Given this list of marker genes ADH7, AKR1C2, HSD3B2, DKK3, SRD5A3, FURIN, DHRS11, ARNT, SRD5A2, MEP1A, CYP46A1, NAGLU, SLC16A2, KLK6, ZMPSTE24 (NCBI Gene Id 10269), BMP2, ASMT, HSD17B7, RDH16, RDH10, AKR1C1, RDH12, CRHBP, YIPF5, BCO1, CYP3A5, SRD5A1, CTSB, TIPARP, BMP6, CMA1, RETSAT, CYP2C18, FSHB, ADH1C, LIPE, PAX8, DPP4, PCSK1, SLC30A5, RPE65, UGT2B28, CYP19A1, ATP1A1, PCSK6, ACE, ALDH1A3, HSD17B3, STUB1, ADH1B, CYP27C1 (cytochrome P450 family 27 subfamily C member 1), DGAT2, PCSK1N, RDH5, HSD17B2, PTPN11, ERO1B, RDH13, PCSK4, SULT1A4, EGR1, MME, DGKQ, CYP26C1, ADH4, CRABP2, AKR1C4, TSPO, BBS1 (Bardet-Biedl syndrome 1), CPA4, CYP17A1, DIO2, TG, SLC30A8, SELENOM, DUOX1, SDR16C5, SCG5, MBOAT4, CPQ, RBP1 (NCBI Gene Id 5947), GHR, PLA2G7, DUOXA1, UGT2B17, WNT4, SLC16A10, GNB3, HSD17B11, SLC5A5, FSHR, ESR1, PREP, GATA3, PLEKHA1, LRAT, IL4I1, SULT1A3, DUOXA2, ALDH1A1, CYP26B1, UGT1A1, CYP1B1, ADH6, NR3C1, DGAT1, PCSK7, SCPEP1 (NCBI Gene Id 59342), SDR9C7 (NCBI Gene Id 121214), RDH14, AFP, CACNA1H, CYP3A7, ADH1A, SGPL1, MED1, UGT2B11, UGT1A7, CYP26A1, ALDH1A2 (NCBI Gene Id 8854), FFAR3, SPP1, LEP, SLC26A7, HPN, DHRS2, DIO1, FOXA1 (NCBI Gene Id 3169), GHRHR, DHRS4, PNPLA4, IYD, HID1, DHRS9, RBP4, ALDH8A1, CEL, AKR1B10, HSD17B4, DUOX2, ECE2, CTSG, PCSK5, PRLHR, CPE, DISP1, CYP11A1, CPA3, CHST10, CYP2D6, SLCO1C1, INHBA, AKR1D1, LHB, CTSL, CYP2S1, BCHE, SHH, REST, UGT2B10, CYP11B1, GAL, UGT2B7, CYP1A1, DHRS3 (dehydrogenase/reductase 3), ECE1, EDNRB, PDGFRA, ENPEP, UGT1A9, DIO3, HIF1A, SULT1B1, HSD17B1, STC2, ATP6AP2, DHRS7, SULT2A1, ADM, CHST8, ADAM10, BCO2, PCSK2, AKR1C3, TPO, CRYM, AKR1B1, HSD17B8, PNPLA2, NR5A1, SCP2, FOXE1, CHST9, AWAT2, CYP21A2, CYP3A4, LHCGR, ANPEP, UGT1A8, NR5A2, STAT5B, DDO, CYP1A2, AKR1B15, GCNT4, CYP11B2, PRCP, CGA, BACE2, H6PD, HSD17B12 (hydroxysteroid 17-beta dehydrogenase 12), SCNN1B, PLB1, CYP2C8, HSD17B10, CTSZ, PNLIP, STARD3, PDE8B, ACE2, UGT2B4, BMP5, CYP2C9, HSD17B6, SULT1A1, IDE, P4HB, RDH8, SULT1E1, AANAT, PRMT3, UGT2B15, RDH11, PAPSS2, CLCN2, HSD3B1, FDX1, UGT1A3, POR, CTSK, TCF7L2, DAB2, CORIN, HFE, REN, CYP2W1, here is a description of the gene set: Human Gene Set: GOBP_HORMONE_METABOLIC_PROCESS The chemical reactions and pathways involving any hormone, naturally occurring substances secreted by specialized cells that affects the metabolism or behavior of other cells possessing functional receptors for the hormone. studied in species Homo sapiens